The following is a description of a gene set: Mouse Gene Set: GOCC_NEURONAL_DENSE_CORE_VESICLE A dense core vesicle (granule) that is part of a neuron. These vesicles typically contain neuropeptides. They can be found in all parts of neurons, including the soma, dendrites, axonal swellings (varicosities) and synaptic terminals. studied in species Mus musculus, and this is the list of marker genes: Plat, Cadps, Bdnf, Vps13a, Chga, Syt4, P2rx2, Plcb2, Stxbp5, Oxt, Calcrl, Dvl1, App, Avp, Oprd1, Crh, Npy1r, Adrb2 (NCBI Gene Id 269028), Slc18a2, Sst, Stxbp5l, Grp, Htr1d, Kif1a, Adcyap1, Cacna2d1, Ghrl, Pdyn, Hcrt, Igf1, Adrb1, Scg2, Gnai2, Penk, Dmxl2, Npff, Calca, Npy, Fzd8, Syt5